The following is a description of a gene set: Mouse Gene Set: GOBP_AXON_EXTENSION species: Mus musculus Long distance growth of a single axon process involved in cellular development., and this is the list of marker genes: Mag, Rnf6, Ndel1, Disc1, Slit1 (NCBI Gene Id 226119), Mir124a-1, Mir124a-2, Clasp2, Dclk1, Nlgn3, Rtn4, Sema6d, Wdr36 (NCBI Gene Id 70569), Mgll, Cdkl3, Barhl2, Dcx, Auts2, Cttn (cortactin), Actr3, Twf2, Ilk, Rufy3, Draxin, Ngf, Sema5a, Sema6c, Slit3, Map1b, Zfyve27, Golga4, Ifrd1, Rtn4r, Dvl1, Gdi1, Eif2b2, Megf8, Smurf1, Myo5b, Cyfip1, Arhgap4, Bdnf, Trpv2, Ccr5, Ptprs, Sema5b, Rab21, Pou4f3, Vegfa, C9orf72, L1cam, Map2, Fxn, Sema7a, Fstl4, Ep300, Cdh4, Abl1, Anapc2, D130043K22Rik, Vcl, Cdkl5, Mapt, Sema3a, Pak1, Eif4g2, Wnt3, Srf, Dbnl (drebrin-like), Dnm2, Shtn1, Dbn1 (NCBI Gene Id 56320), Ulk2, Fn1, Trim46, Sin3a, Cxcl12, Macf1, Cdh1, Edn2, Pou4f2, Arhgap32, Trpc5, Sema3g, Plxna4, Lhx2, Dscam, Plxna3, Ednra, Alcam, Islr2, Spg11, Slc9a6, Edn1, Ndn, Ntn1, Wnt5a, Usp9x, Gsk3b, Sema4f, Itgb1 (NCBI Gene Id 70812), Adcy10, Edn3, Tnr, Ssna1, Ttl, Sema3f, Cdk5, Nkx6-1 (NK6 homeobox 1), Adnp (NCBI Gene Id 98815), Dip2b, Rpl4, Ttc3, Wnt3a, Apoe, Ulk1, Raph1, Hdac6, Limk1, Nrp2, Lamb2, Smo, Olfm1, Mt3, Lrp1, Nrp1, Ntrk3, Ryk (NCBI Gene Id 20187), Map3k13, Pafah1b1, Bmpr2 (bone morphogenetic protein receptor type 2), Tnfrsf12a, Slit2